The following is a description of a gene set: Human Gene Set: CHICAS_RB1_TARGETS_SENESCENT studied in species Homo sapiens from publication Chicas A, Wang X, Zhang C, McCurrach M, Zhao Z, Mert O, Dickins RA, Narita M, Zhang M, Lowe SW (PMID 20385362) The RB protein family (RB, p107, and p130) has overlapping and compensatory functions in cell-cycle control. However, cancer-associated mutations are almost exclusively found in RB, implying that RB has a nonredundant role in tumor suppression. We demonstrate that RB preferentially associates with E2F target genes involved in DNA replication and is uniquely required to repress these genes during senescence but not other growth states. Consequently, RB loss leads to inappropriate DNA synthesis following a senescence trigger and, together with disruption of a p21-mediated cell-cycle checkpoint, enables extensive proliferation and rampant genomic instability. Our results identify a nonredundant RB effector function that may contribute to tumor suppression and reveal how loss of RB and p53 cooperate to bypass senescence. Genes up-regulated in senescent IMR90 cells (fibroblast) after knockdown of RB1 by RNAi., and this is the list of marker genes: CACYBP, FBXO11, DDX60, PELI1, AKAP12, GTPBP10, NCAPG2, PRKDC, PDZK1 (PDZ domain containing 1), ENSG00000269825, BEX1, FMC1, EIF4EBP1, SNX7, CSTF3, ACTG2, AREG, TMEM106C, LSP1P5, PTX3, CERS6, MALAT1 (metastasis associated lung adenocarcinoma transcript 1), ESM1, C3, RBBP7, SMC3, HLA-B, RIF1, ARL6IP6, ZEB1, VASH1, IL24, CTDSPL2, ZG16B, RNASEH2A, TNFAIP8, ACKR3, CASP8AP2, PSMC3IP, POU2F2, TIPIN, MMP9, RRM1, MELK, PRIM1, CST2 (cystatin SA), GBP3, CST4, TEX30, GMPS, UHRF1, SLC39A8, RANBP1, HIP1, PHGDH, TNP1, ERGIC1 (endoplasmic reticulum-golgi intermediate compartment 1), RIPK2, EIF5-DT, PDP1, SLC25A36, MSH2, SLC7A1, CXCL11, UBE2T, RASSF8-AS1, MMD, TNFSF15, SRRM2, FERMT1, KCTD12, RHOF, GNB1 (G protein subunit beta 1), SIMC1, DDX24, PTP4A2, WDR76, TBX2-AS1, EZH2, ZNF83, RBBP8, LAPTM5 (NCBI Gene Id 7805), EMP1, POGLUT3 (protein O-glucosyltransferase 3), MAST2, SLBP, SNORD7, HIPK2, AKR7A2, MCMBP, THRAP3, PPIL3, NUCKS1, ABHD3, PCLAF, ADD3, SEL1L3, USP1, IL6, RPA1, BBS2, CD69, WDR54, CNRIP1, C11orf54, ISG15, MBD4, ENSG00000294531, PTN, RASSF3, DTX3L, CLGN, WDFY2, VCAM1, NUSAP1, TTC3, PRKD3, KLHL7, FANCG, MLLT6, YY1, HEY1 (NCBI Gene Id 23462), THY1, PRXL2A, CEP15, PAQR5, PCNA, SANBR, DGAT2 (NCBI Gene Id 84649), TIFA, MRI1, CDT1 (NCBI Gene Id 81620), ITGBL1, CDC7, MTR, CXCL3, BTN3A3, KYAT3, SLFN11, IFNGR2, CDK2, TCEAL3, PPBP, CENPX, SERPINA1 (serpin family A member 1), FKBP11, LRRC15, GJB2, SAMHD1, TRIB2, HACD3, ACYP1, CTH, JDP2, HAT1, OSMR, SLC5A3, IFT80, CENPK, CDC6, SLAMF8, RFTN2, SYNJ2, TPR, SAC3D1, NRG1, PLSCR1, TMEM97, PTMA, GNG2, VWA5A, SPATA18, PITPNC1, PREX1, WASL, PIDD1, INHBA, NSMCE4A, PSIP1, CLDN5, CTSS, AGGF1, SMC6, ENOSF1, CDCA7L, DNAJC18, HADH, POLD3, MCUB, DNM1, JUN, TM6SF1 (transmembrane 6 superfamily member 1), SLC30A4-AS1, CAMTA1, TYMS, ANP32B (acidic nuclear phosphoprotein 32 family member B), IL11, RAB27A, ZDHHC6, CKMT2-AS1, TMPO, SDC3, MCM7, CHST2, UBE2L6, TCIRG1, HAUS2, PRRX1 (NCBI Gene Id 5396), BGN, RBCK1, EGR3, THBD, IFIT3, PSMB8, MEA1, DSN1, IFI6, SRD5A3, MLPH, APCDD1L, SERPINB3, CCL20, PRSS3, ANPEP, ITPRIPL2, GINS2 (GINS complex subunit 2), DIRAS3, CSF3, WWTR1, PI4K2B, UQCC2, EDNRA, LDB2, RDH10, GALNT6, DDIT4, NLRP1, C11orf96, ANKRD9, IL6ST, DERA, LMNB1, GON7, BAALC, MCUR1, CYP3A5, CYGB, POSTN, CDC25A, PRSS3P2, EHF, GMNN (NCBI Gene Id 51053), TRPC1, TOP1, FBXO21, NRGN, DCK, PHF19, SESTD1, GXYLT1, CXCL1, RRM2, FGD5-AS1, CYB5R2, CCNE2, RPA3, TAGLN3, SMAD5, FBXO45, CCNE1, C15orf48, VNN1 (NCBI Gene Id 8876), FZD1, MAP4, CEBPZ, RAB31, SON, PRRC2C, TMEM132A, GABRB1, ISG20, SKA2, RASL12, PTGS2, PMS1, LGALS3BP, HELLS (helicase, lymphoid specific), G0S2, RFC4, DCBLD1, NET1, GJC1, NAV1, TSC22D1, RAB38, ST3GAL1, RHOBTB3, SPEN, CEMIP, BTN3A2, FRMD4A, TREM1, CD274, GAL (NCBI Gene Id 51083), GLUL, RNASET2, FLT1, IL33, IGFBP5, LRFN5, CPNE2, IFT25, ATRX, CXCL6, RFLNB, SNRPB, SERPINB7, SLC27A3, HMGN2, SERPINE1, FAH, NETO2, SLC25A40, IL27RA, GEM, ACBD3, SPDL1, DYNC2I2, LUZP1, SPIN4, PSME2, CRIP1, RNF168, WDHD1, KRAS, CYB5A, IRF9, ZNF367, CEP19, CLIP1, FOXQ1, MRPS6, HMGA2, FANCI, HPRT1, ZNF846, FADS1, CBX5, IL1A, LIF, TCEAL7, SLC20A1, NIBAN1, DPYSL3, IL37, CYP26B1, LPP, TRMT5, IGF2, SMARCC1, DTL, STMN3, VRK2, TXNIP, PLTP, DDB2, ARMCX2, CXCL2, DNAJC1, CBR3, CCDC71L, MACROH2A1, FEN1, FAF2, BBX, HAS2, NME7, DYNC1H1, NOL4L, MXRA5, NUDT21, NUCB2, MMP10, SDHAP3, CYBRD1, PRTFDC1, GPD2, ERAP2, MSH6, ING2, LRP11, CAMK2N2, PRR11, MCM6, SLC7A2 (solute carrier family 7 member 2), NUP85, SOX17, GLIS3, GINS1, THAP9-AS1, CHI3L1, SF3B1, CDK5RAP2, IFITM1, PAICS, ATP1B1, PLEK2, DIP2C, BEAN1, ATAD2, GCH1, SOX11, MAGEF1, LINC00342, TMEM54, BMAL2, MCM3, CXCL10, PAXIP1-DT, OXCT1, FBXL21P, SKP2, PAWR, FUT8, COL6A2, CCL3, MTHFD1, MYH10, RBM39, CXCL5, IVNS1ABP, COMMD4, CA12, S100PBP, PDLIM3, OSBPL8, DIO2, ACOT7, VEGFA (NCBI Gene Id 7422), BRD3OS, GUSB (NCBI Gene Id 2990), RMI1, MCM2, SLC2A4RG, CENPS, BCL2A1, BTG3, EXOSC8, KCNG1, SMC1A (NCBI Gene Id 8243), CST1, HDGFL3, JARID2, TALAM1, BDKRB2, OXR1, SDHAF4, COL7A1, MMP12, GCLM, STING1, MCM5, LANCL1, MIB1, RNF138, SCG5, RBBP4, ACADM, NASP, IDH2, SRGAP2B, RFWD3, TGIF1, CCNB1IP1, RAB27B, ALDH1A3, DONSON, HPSE, NAMPT, ABTB3, PRRT2, CSF2, GK, KPNB1, PCOLCE, SLC14A1, MLH1, IGFBP3, MEDAG, ENC1, MCM4, GFPT2, ZBTB38, ENO2, DUT, HSPA4L, CD82, SMOC1, PLAGL1, CKLF, EFS, ODC1, TBX3, WEE1, SERPINA9, TUBG1, TRIB3, TSPAN5, COL10A1, XIST (NCBI Gene Id 7503), THBS2, SLC43A3, JAM2, FEZ1, NFKBIZ, NR2F1-AS1, SEMA4B, EMP2, ABI2, SERPINB4, CYP3A7, CEP57, FBL, DUSP5, CISD2, CDC42BPA, ERCC1, CDCA7, BRI3BP, QPCT, PRPS2, RGS17 (NCBI Gene Id 26575), RGS5, TSLP, C9orf40, GSAP, TNFAIP3, NQO2, HAUS1, C6orf136, FAM114A1, SFR1 (NCBI Gene Id 119392), DEK, STEAP1, DHFR, SLC25A37, RFC2, GLCCI1 (NCBI Gene Id 113263), CENPU, UBR7, GDNF, ALDH7A1, RASD1, APOBEC3G, ACP3, TMEM107, TRIM56, NAP1L1, SP100, PI3, LRIG1, KANK2, CENPV, NSD3, BIRC3, SLCO4A1